Given this list of marker genes SLC4A1, GATA1, KCNE5, EPB41, GYPC, AMMECR1, TRNT1, NHLRC2, CA2, ACSL4, SPTB, SPTA1, here is a description of the gene set: Human Gene Set: HP_ELLIPTOCYTOSIS The presence of elliptical, cigar-shaped erythrocytes on peripheral blood smear. Elliptocytosis studied in species Homo sapiens